Given this list of marker genes CHML, ZBTB20, DHX33, RUNX1, SRRM1, RAB4A, FAF2, HOXB2, MCEMP1, HDAC2, ZNF217, MMGT1, NFIC (nuclear factor I C), NSD3, TCF7L2, CEP170, CERT1, ZNF776, SURF1, DCAF11, DNAJB14, ALKBH5, ZNF652, RPUSD3 (RNA pseudouridine synthase D3), LYPLAL1, NAT1, SLC35D1, KIDINS220, DNAAF2, PIP4P2, RGP1, PRKACA, PTGER2, MEGF9, PGAP6, CYBB, WFDC21P, CDC23, USP9X, CYP27A1, RAP2A, LPCAT1, H2AZ2, DENND11, INTS6, TMEM170B, ZNF148, CDKN2AIP, CIRBP, G2E3, RAB8B, SERINC5, ZNF782, CHD7, CALML4, ITPRID2, SETD1B, PBX3, SLC27A4, MALSU1, AKAP11, MSL2, CEP192, TSG101, S100P, GRK3, USP28, RRAGA, RDH11, WDR37, ZBED5, TAPT1, BPNT1, DOCK5, ABL1, NDUFA8, FAM76B, RAD23B, KLHL9, STMP1 (short transmembrane mitochondrial protein 1), TNRC6B, DESI2, ECI2, GLCE, JTB, NLRC4 (NCBI Gene Id 58484), TAOK3, ATP5F1C, CERS2, PLPP3, RIOK2, PDK1, ZFP36L1, VPS26B, CLSTN1, DENND2D, SPDL1, MKRN1, NR1D2, TMEM52B, MYC, SEPTIN7, FH, EPRS1, HUS1, ASB1, CHPF2, MPHOSPH8, ASAH1, GALNT1, TPST1, ADIPOR1, MEX3C, TRAK2, C6orf62, CCDC88A (NCBI Gene Id 731560), MED30, TMEM147, ATG2B, ZZEF1, AGO3, NFYB, SLC49A4, GOLM2, GNG12, ZMYND11, SPOPL, NFU1, PINK1, C2CD2, EML4, PRPS1, ACAD8, LPP, ZBED1, TRAPPC8, ANP32B, CDC40, DPY30, CSNK1E, TMEM14C, FAM221A, UBAC2, CAMTA1, ETFRF1, SULT1A1, BCL2L12, COMMD3, AASDH, SLAIN2, SARAF, RNPC3, CCNH, RANBP6, CHST7, TGS1 (trimethylguanosine synthase 1), DTX4, FYN, KMO, WNK1, CNOT6L, THBS1, SNX30, KLHL15, FBXO9, MPHOSPH6, WBP1L, NCOR1, C6orf120, SEMA3C, SLC19A2, HSD17B4, TUBG1, CCDC186, NEDD4L, MMP7, UBR5, PDE8A, TULP4, NUP133, ZNF470, SNX1, AFG2B (AFG2 AAA ATPase homolog B), SERINC3, MZT1, TMCO3, S1PR3, CD81, NDUFS1, GAS2L3, MAPK1, PPP3CA, CCDC14, HAUS1, RWDD4, CPQ, CEPT1, HOMER3, PABIR2, here is a description of the gene set: from publication Tassiulas I, Hu X, Ho H, Kashyap Y, Paik P, Hu Y, Lowell CA, Ivashkiv LB (PMID 15467722) Genes down-regulated in monocyte-derived macrophages: no priming versus primed by IFNG. Type I IFN-inducible gene expression in human blood monocytes primed with Type II IFN. studied in species Homo sapiens Human Gene Set: GSE1740_MCSF_VS_MCSF_AND_IFNG_DAY2_DERIVED_MACROPHAGE_DN